Given this list of marker genes RMDN3, LRRC37A16P, FBXL17, ZZEF1, ZFP36L1, TRIM44, MYOT, PLCB3, OAS2, HSPA4L, KHNYN, NUP93, SNX17, RUFY3, MMAB, CH25H, EHBP1, SCARB1, C1QB, CYP3A43, PLPP3, MFAP5, DENND1B, ST6GALNAC2, FAR2, LRRC52-AS1, TMEM182, PIGV, EI24, RAB33B, TOE1, NSD2, STAT1, LPAR1, DPAGT1, TARDBP, ACSL3, PEX12, UBE2L6, METTL23, NDUFC1, MTRR (5-methyltetrahydrofolate-homocysteine methyltransferase reductase), BCL2L11, ECH1, SLCO3A1, LINC01785, ZNF92, DYNLL2, DPH7, CXorf38, SURF1, HERC5, PNPLA1, TLR4, FIG4, OPN3, CFAP161, APCDD1L, CPT1A, REV3L, MGLL, CYP7A1, DCUN1D5, DUSP5, ESM1 (endothelial cell specific molecule 1), DTX4, SURF2, DCTD, UBB, RPIA, PTHLH, STARD4, FMNL2, RNF2, ZDHHC3, NIT2, USP26, IL10RB-DT, BRDT, PRR32, PLIN2, APOL6, KDM4C, GRK3, HHLA2, SLC12A6, MRPL23, OAS1, LINC00639 (long intergenic non-protein coding RNA 639), ETFB, VRK1, PGM1, DUOX1, TMEM135, UBL5, EBLN3P, PLA1A, MSTN, RCN1, WDR82, RNF7, PCLAF, ETFDH, INF2, GARS1-DT, ZFAND1, S100P, IFNAR2, EXOC3L4, ADAM17, C16orf92, GLS, BMX, THBD, XPO5, PCOLCE2, SOWAHC, CTSD, COMMD1, PTPN22 (protein tyrosine phosphatase non-receptor type 22), TTPAL, PUM1, MRPL14, TMA16, FAM234B, COQ5, ZNF451, CCNJ, PARP14, SYNGR2, CENPA, IL22RA1, APOO, FADS2, NOC3L, MX2, NUBP1, FAM222B, EVA1C, TMEM53, CDC42BPA, PRKDC (protein kinase, DNA-activated, catalytic subunit), SLC19A2, FCGRT, MOGAT1, CCNE1, SOX7, AKR1B1 (aldo-keto reductase family 1 member B), SCD, SLC37A1, NIPSNAP3B, EEF2K, ACVR2A, LINC00851, IL18R1, ZSCAN2, CPA5, NDUFA10, ZNF664, DDC-AS1, GPN1, NUP50-DT, SLC36A4, ST7-OT4, FCER2, PCDHGA10, FAIM, MPHOSPH6, JPT2, PSME2, PDK4, PDE8A, NSUN2, C1QC, TMCO6, PUS7, GSDMD, PSMD4, DSPP, DEGS1 (delta 4-desaturase, sphingolipid 1), TMEM87A, NUDT10, TARP, MFHAS1, PHYH, GRAP2, C6orf226, KCNE1, ZBED5, UROS, MFSD2A, FAM223A, CD82, CCT7, NSMCE4A, DAG1, here is a description of the gene set: Human Gene Set: GSE1791_CTRL_VS_NEUROMEDINU_IN_T_CELL_LINE_3H_DN Genes down-regulated in D10.G4.1 T cell line (3h): control versus treated with NMU. Effects of Neuromedin-U on gene expression in mouse D10.G4.1 T-cells natively expressing the GPCR Axor13 from publication Johnson EN, Appelbaum ER, Carpenter DC, Cox RF, Disa J, Foley JJ, Ghosh SK, Naselsky DP, Pullen MA, Sarau HM, Scheff SR, Steplewski KM, Zaks-Zilberman M, Aiyar N (PMID 15585845) studied in species Homo sapiens